The following is a description of a gene set: Reactome Pathway: Interleukin-38 signaling studied in species Homo sapiens Interleukins are immunomodulatory proteins that elicit a wide array of responses in cells and tissues. Interleukin 1 family member 10 (IL1F10, IL 38) is a member of the IL1 family. IL1F10 is selectively produced by human apoptotic cells and human epidermal keratinocytes (based on mRNA studies) (Boutet M A et al. 2016). IL1F10 can bind to interleukin 1 receptor like 2 (IL1RL2) and may result in the suppression of IL 17 and IL 22 and induction of IL 6 production (van de Veerdonk et al. 2012, Mora et al. 2016). IL1F10 is synthesized as precursors that require N terminal processing to attain full receptor agonist or antagonist function. Both full length (1 – 152 amino acids) and N terminal truncated (20 – 152 amino acids) IL1F10 can bind Interleukin 1 receptor accessory protein like 1 (IL1RAPL1). The binding affinity of truncated IL1F10 is much higher than that of the full length. However, binding of the full length or truncated forms has distinct outcomes; the former induces IL6 and the latter suppresses IL6 via JNK and AP1 signaling. part of: Interleukin-1 family signaling, and this is the list of marker genes: MAPK8, IL1F10, IL1RAPL1, IL1RL2